The following is a description of a gene set: The directed movement of L-alanine across a membrane by means of some agent such as a transporter or a pore. studied in species Homo sapiens Human Gene Set: GOBP_L_ALANINE_TRANSMEMBRANE_TRANSPORT, and this is the list of marker genes: SLC3A2, SLC38A4, SLC7A8, SLC1A4, SLC38A5